The following is a description of a gene set: from publication Chen Y, Wang X (PMID 31504780) Genes predicted to be targets of miRBase v22 microRNA mmu_miR_219b_3p in miRDB v6.0 with MirTarget v4 prediction scores > 80 (high confidence targets). Mouse Gene Set: MIR_219B_3P species: Mus musculus, and this is the list of marker genes: Peg10, Piga, Scgb1b29, Ndor1, Slc25a32, Foxn2 (forkhead box N2), Dpp10, Sod3, Scgb1b20, Glrb, Ttll7, 9230112D13Rik (RIKEN cDNA 9230112D13 gene), Jade1, Asph, Ppp4r3c2, Magi3, Fabp7, Mterf2, Zfp28, Slco1c1, Yod1, Abhd17b, Iqgap2, Epha4, Otud7b, Sgip1, Phtf2, Eomes, Mettl21c, Rab6a (RAB6A, member RAS oncogene family), Camk1d, Cdh12, Ccdc68, Aff4, Eif2s3y (NCBI Gene Id 26908, eukaryotic translation initiation factor 2, subunit 3, structural gene Y-linked), Kmt5b, Steap2, Arpp19, Neurod1, Fnip1, Satb1, Scgb1b7, Tubb4b, Chrna3, Plec, Lactb2, Ttyh3, Zfp84